Given this list of marker genes B4GALT1, here is a description of the gene set: species: Homo sapiens Reactome Pathway: Defective B4GALT1 causes CDG-2d part of: Diseases associated with N-glycosylation of proteins Congenital disorders of glycosylation (CDG, previously called carbohydrate-deficient glycoprotein syndromes, CDGSs), are a group of hereditary multisystem disorders. They are characterized biochemically by hypoglycosylation of glycoproteins, diagnosed by isoelectric focusing (IEF) of serum transferrin. There are two types of CDG, types I and II. Type I CDG has defects in the assembly of lipid-linked oligosaccharides or their transfer onto nascent glycoproteins, whereas type II CDG comprises defects of trimming, elongation, and processing of protein-bound glycans. Clinical symptoms are dominated by severe psychomotor and mental retardation, as well as blood coagulation abnormalities. B4GALT1-CDG (CDG type IId) is a multisystem disease, characterized by dysmorphic features, hydrocephalus, hypotonia and blood clotting abnormalities.